The following is a description of a gene set: Human Gene Set: GOBP_RESPONSE_TO_INTERLEUKIN_6 studied in species Homo sapiens Any process that results in a change in state or activity of a cell or an organism (in terms of movement, secretion, enzyme production, gene expression, etc.) as a result of an interleukin-6 stimulus., and this is the list of marker genes: MIR146A, ST3GAL6, SRC, SBNO2, RELA, PTPN2, MIR98, MIRLET7A1, C1QTNF4, IL6R, FER, FCAR, MIRLET7E, MYB, MIR99A, IL6, IL6ST, CITED1, MIR26A1, SPI1, SMAD4, MIR125A, JAK2, NFKB1, PID1, CHI3L1, YAP1, RIPK1, JAK1, LCN2, SELPLG, PTGIS, MIR149, MIR125B1, ST18 (ST18 C2H2C-type zinc finger transcription factor), MIRLET7C, FOXA2, CTR9, CAMP, FGF23, STAT4, GFI1, PHB1, PTPRT, STAT3, CRIPTO, CFL1, CEBPA